The following is a description of a gene set: Neighborhood of CENPF centromere protein F, 350/400ka (mitosin) in the GNF2 expression compendium Neighborhood of CENPF Human Gene Set: GNF2_CENPF species: Homo sapiens, and this is the list of marker genes: MT1JP, MCM2, RFC4, KIF11, SMC4, RRM2, CCNA2, TMPO, CDK1, UBE2C, HMMR, MYBL2, CCNF, NSD2, UBE2S, PLK4, TPX2, RRM1, TYMS, NDC80, PCLAF, KIF4A (NCBI Gene Id 55595), PTTG1, ZWINT, TTK, PRIM1, KIF15, HJURP, CDC20, CENPF, AURKA, ASPM, MCM7, SMC2, KIFC1, FEN1, PCNA, KIF18B, CKS2, CDCA8 (cell division cycle associated 8), CENPE, NUSAP1, HAT1, PRC1, TOP2A (DNA topoisomerase II alpha), MKI67 (marker of proliferation Ki-67), DNAJC9, E2F8, HMGB2, SHCBP1, CKAP2, MCM10, GINS2, CCNB2, FANCI, H2AX, DTYMK, MCM3, FOXM1, BIRC5, DLGAP5, CDCA3